Given this list of marker genes SOX8, CEACAM5, ACTC1, ITGB1BP2, PKP2, H1-5, TBX5, ARRB2, BMAL1, DSP, CFL2, POPDC3, FLOT1, XBP1, CCNT2, MYH6, MYEF2, MYOZ2, FOXL2, MIR1-1, CD81 (NCBI Gene Id 975), ERO1A (NCBI Gene Id 30001), PTBP1, PAXBP1, COL19A1, USP2, MEF2D, OBSL1, PARP2, SPEG, TBXT, JPH2, ZFP36L1, KAT2A, SYPL2, MYLK, HLX, ACADM, BORCS8-MEF2B (NCBI Gene Id 731041), LEF1, MYL2, ADGRB1 (NCBI Gene Id 575), MECP2, TLL2, ANKRD23, LMOD1, ADGRB3, RPL3L, YBX3, HEY2, BMP10, DMRTA2, MTLN, PPP3CB, GPER1, CAMK1, ATG5, MIR145, ASNSD1, MIR222, DLL4, MIR133A1, ADAMTS15, NACA, ADM, DCANP1, ARID1A, CENPF, COL14A1, ATF3, NFATC3, COMP, GREM1, RXRB, PAK1, CD9, DES, PI16, RARA, CNTFR, EGR1, ID3, FKTN, GMPPA, MIR208A, MIR21, ZMPSTE24, FOXO4, MYH15, DDIT3, RARB, NINJ1, C10orf71, SRA1, CASP7, TANC1, FGFRL1, OBSCN, ARID5B, WFIKKN1 (NCBI Gene Id 64491), IFT20, CTCF, CDK5, MEGF10, MEIS1, LMNA, PRICKLE4, UNC45B, HOXD9, BVES, GSK3A, ANHX, SIRT1, BMPR2, ZNF689, COL11A1, P2RX2, KDM1A, ASS1, BARX2 (BARX homeobox 2), SCN11A, RBM38, B4GALNT2, EEF2, LIF, TCF12, DKK1, ACTB, VAMP5, PPARA, KRT19, PDLIM4, HSPB2, KEL, MIR34A, TGFBR1, MIR143, RYR2 (ryanodine receptor 2), EHD2, NID1, CHRNA1, NPHS1, MIR499A, ALPK3, NOG, MIR195, MED20, RGS4, TNNC1, RAMP2, LMOD2, FZD1, EPAS1, TOMM70, GPX1, NPPA, KMT5B, SPAG9 (sperm associated antigen 9), ASF1A, MYH9, PTGFRN, BMPR1A, XIRP1, BDNF, RGS2, ITGA7, FGF6, MEF2C, ACTN4, DAG1, MAP3K5, MYLK3, LAMB1, CFLAR, MIR23A, ERVW-1, RBPJ, GTF3C5, HLF, TMEM204, SMAD3, MED1, KLHL40, MBNL3, MTM1, NOTCH4, SOX11, PRKD1, FKBP1A, MIR590, AFG3L2, PRKAA1, NEO1, ERVFRD-1, CHRND, CDK9, XK, FHL1, HNRNPU, TMOD2, NOTCH2, MRTFA, CBY1, TSC1, NOX4 (NADPH oxidase 4), RORA, MAPK12, MUSTN1, COL3A1, NOTCH1, PAX5, PDLIM2, VRK3, BCL9, LOX, MYBPC1, FBXO22, CXCL9, CAPN3, ANKRD33, GLMN, SFMBT1, IL18 (NCBI Gene Id 3606), SLC9A1, CHKB, SCX, MIR19B1, SRPK3, ETV1, CASP3 (caspase 3), DMPK, TMEM119, SGCD, APLNR, ANK2, FOXN2, PIEZO1, ISL1, NRAP, MYL3, MIR424, RYR1, ACTA1 (NCBI Gene Id 58), SMTN (smoothelin), MIR221, TCF21, ACTN3 (actinin alpha 3), STRA6, EP300, TMEM182, MCUB, ZNHIT1, EGLN1, PRICKLE1, SGCE, SCGB3A1, ACTN2 (actinin alpha 2), DPF3, EFNB2, SGCG, ZFPM2, MYL6, SMARCE1, GPC1, MYOZ1 (myozenin 1), S1PR1, HDAC1, PPP2R3A, XIRP2, VGLL2, DNMT1, SOX15, RHOA (NCBI Gene Id 387), IRX3, FZD7, H3-3B, TBX18, FGF10, SGCB, PAX3, SGCA, ADAM12, BCL9L, MYC, MIR125B1, MSX1, MED28, FOXK1, CAPN2, KCNJ8, CD164, TCF23, ADRA1A, KLHL41, CNTF, EHD1, LDB3, DDX5, HDAC3, BHLHA15 (NCBI Gene Id 168620), FOXC2, NEGR1, SOX6, PDGFB, MYLK2, ZBED6, ATP2A2, NR4A1, OLFM2, TGFBR3, TCF15, ANKRD1, NAGLU, OR10J5, TWIST1, MBNL1, TAGLN, PHF10, IGFBP3, HDAC4, PDLIM3, ZNF609, MKX, MAPK14, TNFSF14, MYORG, CAV3, YBX1, LAMB2, SOSTDC1, SOX4, NEBL, EPHB1, KAT8, EID2, MEF2A, GDF3, FKRP, HDAC5, FXR1, POPDC2, NEUROG1, SMYD3 (NCBI Gene Id 81838), MIR204, ACTN1, JAG1, MSTN, ELN, MYBPC3, PDLIM7, BOC (NCBI Gene Id 91653), ATP11A, ERBB3, CTNNB1, TRIP4, NR1D2, RBPMS2, BMP2, BIN1, WDR1, MIR199B, HIRA, CACNB4, FBXO40, TGFB1, TRIM32, AVPR1A, CHRNB1, SKI, VEGFA, MIR15B, NFATC1, DLL1, LARGE1, PHOX2B, MTPN, SORT1, EID2B, TNNI3, MYH11, LAMA2, HOPX, VANGL2, VPS13B, GPCPD1, SMARCC2, EREG, CSRP1, EGR3, MESP1, FOXP1, FOXF1, TNPO2, TNNT1, MIR133B, HDGFL2, YY1, MYBPC2, ACTG1, DOCK2, MYL9, KDM6B, TPM1, VAX1, PRDM6, SMAD7, ALPK2, HINFP, PRR14, KY, ZFPM1, MMP14, ITGA8, HSD17B1, SIRT6, KCNH1, MAMSTR, NMRK2, ZBTB42, WNT1, SMARCD2, ITGB1, SUPT6H, MYO18B, MSC, CHUK, LGALS1, ANKRD2, FHL2, LAMC1 (NCBI Gene Id 3915), CRYAB, SETD3, SPG11, METTL21C, CMTM5, KIT, MIR18A, LMOD3, IGSF8, EFEMP2, TCF7L2, EOMES, BTG1, KRAS, NFATC2, CTH, DNER, SIK1, SMARCC1, CNTNAP1, FZD2, SIRT2 (sirtuin 2), STAC3, MEF2B, PBRM1, CAVIN4, MIR200B, ADPRHL1, PLEKHO1, SEMA4C, PDGFRB, SDC1, TIFAB, IGF2, DDX17 (NCBI Gene Id 10521), MYF6, DCAF8, EZH2, PLEKHM3, AKAP13, BIN3, IGFBP5, SMARCB1, LRRC8A, RCAN1, CITED2, AKIRIN1, SLC8A1, TNNT3, AKT1, SVIL, RBM4, DOCK1, LRRC10, MYOCD, ACTL6B, PDLIM5, DUSP29, LBX2, NUPR1, WT1, NKD1, CD53, RANBP3L, FHL3, USP19, MYF5, MIR140, PPIF, TEAD4, REST, FOS, ACTL6A, MAPK11, HEG1, BNIP2, SOX9, HDAC9, CTDP1, SAP30, ADARB1, SOD2, MYOM1, COL6A3, CACYBP, ZBTB18, SELENON, GATA4, NOS1, HOXA2, MIR100, SERP1, SGCZ, SIX4, UNC45A, MYOG, WNT4, SMARCA4, COPS2, G6PD, SIX1, COL6A1, HBEGF, TARBP2, MYMK, FGFR2, MYL11, MYOM2, FLII, SMO, FOXH1 (forkhead box H1), LBX1, MIR206, DYRK1B, SMYD1, TMOD3, CDON, CACNA1H (calcium voltage-gated channel subunit alpha1 H), AKIRIN2, RIPOR2, BRD7, GATA6, LAMA1, RB1, PLEC, MYH10, PLPP7, MAFF, FRS2, TMOD1, XKR8, EMD, ITGA11, TNNT2, HEYL, TRIM72, CHD2, ZEB1, WFIKKN2, PTCD2, HIVEP3, PRKG1, AKAP6, TBX3, ENG, NFATC4, CACNA2D2, HOMER1, KLF5, PIAS1, CSRP3, GSC, IL4R, PDCD4, PROX1 (NCBI Gene Id 5629), EDN1, LUC7L, CXCL10, CTF1, CAV2, CHD7, ID2, SHH, HMG20B, S100B, LAMA5, TBX1, SYNE1, CDK1, MYPN, MYOD1, ALX4, CACNA1S, FLOT2, NR2F2, UCHL1, ABCC9, UQCC2, IGF1, UTRN, DISP1, SMARCD1, HIF1AN, PDLIM1, RBM24, ARID2, NKX2-6, JPH1, FRG1, CCL8, MIR26A1, MIR199A1, CASQ1, FOXC1, MTOR, UBE4B, WNT2, TGFB2 (transforming growth factor beta 2), TNF, SMTNL1, NPNT, KAT5, FOXP2, CCNB1, CALR, HOXD10, CXADR, MYL6B, SMARCD3, PPP3CA, DOCK5, MYH14, VPS54, EVC, SRF, WNT3A, TNNI1, CREB1, CSRP2, MYH7, LRP2 (NCBI Gene Id 4036), ZFHX3, MDM2, EDNRB, WNT5B, H3-3A, NEB, WNT10B, TCAP, MEOX2, POU4F1 (POU class 4 homeobox 1), FGF3, CCN3, IFRD1, BCL2 (NCBI Gene Id 596), PRKAR1A, ASB2, MIR22, PITX1, FGF8, MIR19A, SMARCA2 (NCBI Gene Id 95083), CDH2, GDF15, BMP4, MYMX, CAV1, HEY1, PAX7, NKX2-5, BTBD1, ARK2C, GREB1L, TBX20, SYNPO2L, FLNC, SMAD4, PLG, PPARD, MIR24-1, MAML1 (mastermind like transcriptional coactivator 1), CHODL, NLN, HAND1, COPRS, FHOD3, MYOM3, ADAMTS5, NEURL1, SMAD1, MYBPH, PLD3, MYH3, EDNRA, NRG1, QKI (QKI, KH domain containing RNA binding), TTN, POU6F1, TMOD4, MRTFB, FGF9, SORBS2, LEMD2, BASP1, CYP26B1, EGR2, NF1, BTG2, PITX2, SKIL, ACVR1, PGM5, ARID1B, PDGFRA, SHOX2, FLNB, TBX2, BHLHE41, HES1, PLCB1, DMD, here is a description of the gene set: studied in species Homo sapiens Human Gene Set: GOBP_MUSCLE_STRUCTURE_DEVELOPMENT The progression of a muscle structure over time, from its formation to its mature state. Muscle structures are contractile cells, tissues or organs that are found in multicellular organisms.